Given this list of marker genes PTPRQ, INPP5J, OCRL, INPP5K, INPPL1, FIG4, INPP5E, INPP5D (inositol polyphosphate-5-phosphatase D), here is a description of the gene set: 1,2-diacyl-sn-glycero-3-phospho-(1D-myo-inositol-3,4,5-trisphosphate) + H2O = 1,2-diacyl-sn-glycero-3-phospho-(1D-myo-inositol-3,4-bisphosphate) + phosphate. Human Gene Set: GOMF_PHOSPHATIDYLINOSITOL_3_4_5_TRISPHOSPHATE_5_PHOSPHATASE_ACTIVITY species: Homo sapiens